Given this list of marker genes HSPA1B (NCBI Gene Id 3304), FKBP4, GML, HSPA1L, RPA3, DNAJB1, HDAC6, SERPINH1, CRYBA4, COL4A6, HSF1, HSPB1, YWHAE, HSP90AA1, EEF1A1, RPA1, UBB, TNFRSF21, PTGES3, RLN1 (relaxin 1), RPA2, HSPH1, HSPA1A, MRPL18, HSBP1, DNAJB6, VCP, HSPB2, HSP90AB1, DEDD2, HSPA6, here is a description of the gene set: studied in species Homo sapiens HSF1 activation Human Gene Set: REACTOME_HSF1_ACTIVATION